Given this list of marker genes Fcgr2b, Ighe, Fcgr4, Fcer2a, Fcmr, here is a description of the gene set: species: Mus musculus An endocytosis process mediated by the Fc receptor for the purpose of delivery of antigen-bound immunoglobulin to an intracellular compartment where the antigen can be processed and loaded onto MHC molecules. This process selectively targets antigens for presentation by MHC class II or cross-presentation by MHC class I. Mouse Gene Set: GOBP_FC_RECEPTOR_MEDIATED_IMMUNE_COMPLEX_ENDOCYTOSIS